Given this list of marker genes SMAD6, PLA2G4A, TMPRSS3, MYADM, PLXNB2, ACVR1B, CDH17, RAB31, TMEM51, TTC3, CXCR3, HLF, HCK, ANTXR2, GP9, SOX4, DENND5A, SASH1, SPNS2, LDLRAP1, GEM (GTP binding protein overexpressed in skeletal muscle), SWAP70, UBL3, PTGER3, RNF149, ITGA9, LY86, SHISA2, FYN, RAP2A, ZNF503, CD34, GATA2, ICA1, DOCK7, SLC35F5, KLRD1, HEBP1, LYN, TNFSF14, GLIPR1, ARRDC4, SKAP2, ZNF467, KCTD12, PTPRE, PCYOX1, LGALSL, MITF, TJP1, SERPINA12, CCL5, GFI1B, LRRK1, BTK, RHOQ, TFEC, IL1R2, RGS10, NEK6, MAN2B1, TLCD2, CD81, LITAF, FCGR2A, RAI14, CD7, CD68, C11orf54, ATP8A2, CD180, GKAP1, MEF2C, FES, EID1, ABCB4, SPECC1, NIBAN2, RAB32, MAP4K5, DNMT3A, KCNH2, FGL2, IRF5, CSF1R, BCL11A, THEMIS2, RAMP2, ITGAX, RRAS, ENDOD1, TCEAL1, IL18RAP, PROCR, LBP, KRT7, APP, EEIG1, CALHM5, ARL5A, PRCP, ARRB1, CCR2, TTPA (NCBI Gene Id 7274), ADCY7, GSTM3, CD33, ANXA3, MPO, RORA, IL18R1, CD244, LRP1, DOCK5, ODR4, RGS1, GALNT4, APPL2, MGST1, SIRPA, MFSD6, SAMHD1, TGIF2, S100A4, IER5, ADAM17, MEF2A, JKAMP, CD52, NCF1, HPS3, ANG, SCAF11, OTULINL, TGFBR2, CD44, PAK1, SLC25A45 (solute carrier family 25 member 45), ITGB2, HHEX, SAMSN1, CD300A, STARD8, VSIR, PLA2G15, TSPAN32, ATF6, CASD1, FHOD3, FFAR2, TDRD7, ABCA3, PPP3CA, GCNT2, OGFRL1, SMAD7, SORL1, GCSAM, PLEK, AHNAK, ABCC1, TAL1 (TAL bHLH transcription factor 1, erythroid differentiation factor), IER3, EBI3, PRTN3, SOCS5, DUSP6, GGT5, AQP9, ZBTB14, IRF6, FAM91A1, ANXA1, ST3GAL2, ZNF521, CD86, FASLG, LMO2, TSC22D1, FCRL1, PTK2, CA2, APOBR, ITIH5, STAU2, IL10RB, TYROBP, VAV3, LPCAT1, PARP3 (NCBI Gene Id 25908), IQGAP2, ENTPD1, DAB2IP, C9orf72, MOB1A, RFLNB, CCR5, METRNL, CCND1, RGS18, here is a description of the gene set: Development of T-cells provides a unique opportunity to study cell-fate determination due to the accessability and the well defined stages of developmental stages. In order to understand the genetic programs underlying fetal and adult T‑cell fate specification we subjected highly purified fetal and adult T-cell progenitor populations to a genome‑wide transcriptional analysis. The aim was to identify molecular elements that govern T-cell fate specification as a whole but ultimately to isolate elements that were specific for a given population in a specific developmental window. from publication Belyaev NN, Biró J, Athanasakis D, Fernandez-Reyes D, Potocnik AJ (PMID 22581009) Human Gene Set: GSE24142_EARLY_THYMIC_PROGENITOR_VS_DN2_THYMOCYTE_UP Genes up-regulated in comparison of thymic progenitors versus DN2 thymocytes. studied in species Homo sapiens